Given this list of marker genes SMN1, SPTLC1, TPM2, LRIF1, PABPN1, TRIP4, ANXA11, GDAP1, here is a description of the gene set: studied in species Homo sapiens Angulated muscle fibers Human Gene Set: HP_ANGULATED_MUSCLE_FIBERS Normal muscle fibers are polygonal-shaped in cross section, are multinucleated, and have minimal amounts of endomysial connective tissue. In contrast, angulated (also known as angular) muscle fibers have long and narrow vertices (corners) with sharp edges and a pointed tip.